Given this list of marker genes LRIG1, PGR, MYLK, HEYL, SCX, MYH7, CEMP1, SLC24A4, HES1, ATP6V1B1, PBX1, FGF1, PAX5, ITGAX, RBP4, HDAC1, ADAMTS1, MEIS2, STAT5A, ATG9B, GRXCR1, ABLIM1, IFT52, PTN, LAMB1, HLX (NCBI Gene Id 3142), RPGRIP1, ENSG00000274276, EFNA1, BTRC (beta-transducin repeat containing E3 ubiquitin protein ligase), CELSR1, FOXD1, STAU2, NOS3, NKD1, ID4, GAA, TNFSF11, HAND2, USH1C, DLX5, E2F4, HIPK1, ELF3, SOS1, TPM1, POC1A, GCNT3, NKX6-1, GATA5, ITGB4, LTBP3, CFLAR, ZMPSTE24 (zinc metallopeptidase STE24), HOXA1, ADAMTS19 (NCBI Gene Id 171019, ADAM metallopeptidase with thrombospondin type 1 motif 19), COL8A1 (collagen type VIII alpha 1 chain), NACA, WT1, NOG, PALB2, MTHFD1, APCDD1, DGCR2, TBR1, APLP1, ERBB4, ODAPH, COL8A2, DLL4, AKT3, WNT4, SAV1, RPS6KA1, PEX7, SCRIB, EYA1, AMELX, TP63 (tumor protein p63), APC, SOX18, GRHL3, EFEMP2, ALPL, BBS1, EPHA2, ZFPM1, DCHS1, COL5A2, INHBA, LIF, TBX18, ASXL1, TGFA, RAC1, MDFI, JAG2, BCAR3, NKX2-5, RPGRIP1L, KCNQ4, CRYAA, DSPP, FLI1, MAP2K2, GNAT2, ZNF335, MDM4, TEAD2, GDNF, CPLANE2, BRAF, RNF207, GLG1, C2CD3 (C2 domain containing 3 centriole elongation regulator), HOXA4 (NCBI Gene Id 3201), CRYGB (NCBI Gene Id 1419), FZD2, FOXL2, PPP1R13L, PLXND1, COL13A1, FOXG1, SMAD7, LRP4, BMP2, TTN, HOXC8, HDAC2 (histone deacetylase 2), RFLNA, SOBP, NTN1, EFEMP1, AQP3, ENAM, MYH6, SETDB2, CRB1, STOX1, IL6, LRP5, SLC4A2, SLIT1, SOX4, FGD1, NDST1, RAB33B, UCHL5, NGFR, LGR4, HOXA7, COL2A1, TNFAIP3, EFNB2, SIX4, TMEM100, TH, DYNC2I1, ONECUT2, ZNF22, SLC4A10, HOXB2, EREG, SLC1A1, NTRK2, LTF, PROM1, CPE, TECTA, PKD2, BSG, HOXD9, SMARCC1, NHERF1, PHLDA2, ROBO1, TNF, CSF1R (colony stimulating factor 1 receptor), PITX3, MTOR, TWIST1, RFNG, PAX6, TEK, LEFTY1, POU5F1, BCL2, ARL13B, HEY2, BMP1, TDRD7, NR5A2, EXT2, SNAI1, TULP1, ABCC9, LHX1, HOXB5 (homeobox B5), WLS, CTNNBIP1 (NCBI Gene Id 56998), SOX17, MFRP, ANKRD1, SDK2, NPPC, BSX, FBN1, DSCAML1, TBX5, SERPINH1, ATF2, BARX2 (BARX homeobox 2), FGF4, SLIT3, HOXC11, ZFPM2, LY6H, ARL6, MYL11, KLHL3, RS1, LFNG, MGP, CRIP1, MAPK3, TGFBR2, RUNX2, HOXD13, MAN2A1, GMNN, AJAP1, WNT16, ACVR2B, NPNT, AGT, HOXD8, TMEM59L, MYO15A, COL5A1, BCR, MIR145, BPNT2, FGF16, RYK, NKX2-3, KLHL10, NRP2, FAM20A, FZD1, MIR1-1, AMTN, C12orf57, NF2, TFAP2A, PDX1, PAX3, CHAD, HGF, MSX2, IRX2, MIR17HG, S1PR1, CRX (cone-rod homeobox), WWOX, NTF4, EXT1, XBP1, SEMA3C (NCBI Gene Id 222200), PPARA, RORB, RARB, MED1, SP7, ESR1, FOXI1, HOXD10, ROBO2, FEM1B, NAGLU, BBS4, TAB1, PPP3CA, EDAR, TIPARP, STIL, TGFB1, DCN, RPL13A, ELN, SLC6A4, AHDC1, PBX3, HCCS, FUZ, WHRN, PHOSPHO1, HOXB3, CUL1, THRA, BMPR2, RTN4, BMP5, NR4A3, HACD1, FOXP2, CCN1, ATF4, NR2E3, THRB, CHRNA10, IRX3, MIB1, CLDN5 (NCBI Gene Id 7122), MYF6, ALPK2, OTX1, GPC3, TUFT1, ABI2 (NCBI Gene Id 10152), STC1, CER1, VAX2, TMEM176B, SERPINE1, FRAS1, CTNNA1, AREG, FHL1, PAFAH1B1, FOXI3, PAX4, ISL1, MIR20A, IFT172, HPN, PRKRA, ERRFI1, COL27A1, FGFR1, CELA1, CHSY1, HOXD4, GRHL2, HOXD11, FOXC1, EXOC4, CRKL, NPY2R, TFAP2B, SAMD7, RHOA, TGFBR1, BBS10, MSX1, MDK, SOSTDC1, TNNI3, CNNM4, MESP2, DKK1, KRAS, IMPG2, TRIOBP, TBXT, SEMA6A, NF1, ETV5, NOTO (notochord homeobox), PAPPA2, EZR, HCN1, RFLNB, RP1, MEGF8, FOXJ1, ADAMTS9, BCL11B, VEGFA, IRX5, HOXA5, RBM15, LRP2, DVL2, RING1, PLEKHA1, SOD1 (superoxide dismutase 1), OLFM3 (NCBI Gene Id 118427), IFT57, FGF6, SP5 (Sp5 transcription factor), MMP13, LHX9, DLX1, ITGA2, PTCD2, UBE4B, PDGFRA, SP3, TMEM107, SPARC, DLG5, PKP2, TGFB2, FZD6, SOX11, SMAD6, NECTIN3, FKBP1A, PPP1R35, SRSF6, LAMA1, DLC1, MIR17, BTBD7, STX2, NAB1, CLRN1, WNT10A, MAGED1, CUL3, AGTR2, NOTCH1, AQP5, CBS, TMEM215, HMX2, INSIG1, EMX1, RHO, ROM1, HIPK2, MESP1, FGF7, VEGFC, IRX4, GLI3 (NCBI Gene Id 2737), KDM2B, PDE6C, NDP, FGFR3, BMI1, KIF26B, FOXA1, MSN, HOXB13, DSP, EIF4A3, CDX2, TCF21, PRICKLE1, RXFP1, BMPR1A, DMRT3, MYO3A, DIO3, FLVCR1, CEBPB, RYR1, SKI, ENG (endoglin), SFRP1 (secreted frizzled related protein 1), CEP290, ALX1, STAT6, PTPRM, SPRY2, SNAI2, HOXA11, ANKH, CSGALNACT1, RARA, EPHB1, PHACTR4, PROX1, CCDC39, RAB37, KLK5, ADAM15, SMTNL1, LEF1, WDPCP, PLS1, SAMD11, ASXL3, BMP6, TCF15 (transcription factor 15), FOXF1, FSCN2, HMGN1, TRAF6, FOXN3, ASXL2, ACTA1, BBS2, SALL1, AXIN2, VPS51 (VPS51 subunit of GARP complex), ODAM, TSKU, ALDH1A3 (aldehyde dehydrogenase 1 family member A3), CDKN2A, PAX7 (paired box 7), RARG, PHB2, MEF2C (NCBI Gene Id 4208), SLIT2, DLX6, FGR, NPHP3, TNC, FST, GSK3A, CRB2, COL6A1, MIR19A, BMP4, FHL2, CALB1, NTN4, GDF11 (growth differentiation factor 11), POR, FGL1, SLC39A1, HS3ST3B1, SHOX2, GHR, CHD7, GATA3, ZHX2, WNT9A (Wnt family member 9A), DAG1, TCAP, MEIS3P1, IFT80, BCL2L11, AQP6 (NCBI Gene Id 363), CDC42, PSEN1, PRDM1, TBX2, NPR2, CNTF, ZMIZ1, FGFR2, POU3F4, DMP1, ROGDI, SP6, SPEF2, FGF18, HOXB8, STK40, NCKAP1, NEDD4, NKX2-1, CDH23, CSF1, TMIE, MYBPC3, SLC44A4, USH1G, DLX2 (NCBI Gene Id 1746), ALX3, RIPPLY2, TLE1, MMP2, ARID5B, COL3A1, SGPL1 (NCBI Gene Id 8879), SIX1, COMP, FANCD2, CERT1, WDR48, TGFBR3, TSHZ1, CDON, MYF5, OTOP1 (otopetrin 1), SFRP4, AQP1 (NCBI Gene Id 358), STRA6, TBX15, SLITRK6, NDRG4, ATP8A2, HOXA2, CTHRC1 (NCBI Gene Id 115908), NEUROG1, ITGA6, SOX9, SYNPO2L, TLE2, COL11A1, P2RX7, ACTC1, MTHFD1L, YAP1, CLUAP1, GNGT1, GREB1L, SOX12, CAV1, GAMT, AGTPBP1, TBX3, LIPA, INSR (NCBI Gene Id 3643), ADARB1, MAP2K1, COL1A1, PLXNA1, LIMS2, GRXCR2, FOXE3, FGF10, NRP1, HOXA9, MAPK14, IGF2, HEG1, BBS7, HOXB4, CTNNA2, FZD3, NEUROD1, ALX4, TBX4, ASB2, TNNC1, HS3ST3A1, BMPR1B, MAPK1, ZIC3, EMP2, HOXC13, OSR2, MMP20 (NCBI Gene Id 9313), SIX3, TP53, PTK2, MED12, NRG3 (NCBI Gene Id 219505), SSUH2, TBC1D20, NODAL, WNT2B, TBX1, HRAS, TBX20, NPY1R, PTEN, EP300, COL18A1, REST, GNAT1, TBX19, AMBN, ID1, SHROOM2, CDX1, FBN2, ACVRL1, DNAH11, FAM20C, COL9A1, PKHD1, TLE3, FREM1, JHY, SMAD2, ABCA12, MIR21, LRRK2, AP3B1, WNT7A, SIX6, TAF10, HAS2, LBX1 (NCBI Gene Id 10660), FLRT2, AHI1, GMPPA, JAG1, WWTR1, HESX1, HOXB1, MIR19B1, TCIRG1, TGM2, SAPCD2, ADAMTS5 (NCBI Gene Id 11096), BBS5, RDH13, SYCP2, TNNI1, SLC39A3, HOXC9 (homeobox C9), HOXB7, TMT1A, FGFRL1, HMGA2, GSX2, GATA2, HAND1, TNNT2, WNT7B, LHFPL5, DLG1, HHIP, PRKCI, YY1, SPRY1 (NCBI Gene Id 91129), ARID2, MYO3B, ATG9A, MATN1, ZEB1, SNX10, RELT, NSD2, CITED1, HOXA3, RBPJ, BAX, SOX8, CD34, MKS1, PERP (NCBI Gene Id 64065), TRPV4, CTSZ, RYR2, THY1 (NCBI Gene Id 94105), NFIB, NPY5R, TTC8, DNAAF1, WNT9B, SRC, ADAMTS16, SRF, CAPN1, TNFRSF11B, HNF1A, ZFAND5, GDF7, PAX9, SMO, PRRX1, CCDC40, SATB2, ITGB6, FOXC2, STIM1, HEY1, SFTPB, SOX1, VSX1, XIRP2, FASLG, NFKB1, ACVR1, ADGRG6, EGLN1, ILK, SDK1, DHRS3, SCN10A, STAT3, PAX8 (paired box 8), MEGF11, MDM2, FGF2, NECTIN1, SERP1, SCN5A, CYP7B1, CTSH, MIR195, CEACAM1, INSIG2, HTR2B, FJX1, STRC, DGCR6, DVL1, AMELY, AR, IFT122, BAK1, RELA, ADPRHL1, ACTN3, WNT11, FAT1 (NCBI Gene Id 2195), MYL2, TREH, FRS2, FGF9, CCN2, CTNNB1, MEIS1, PDGFC, TRIP11, FOLR1, ESRP2, CFTR, INPPL1 (inositol polyphosphate phosphatase like 1), SULF2, PLAG1, DDR1, ACVR2A (NCBI Gene Id 92), VDR, MMP14, MFAP2, GBX2, SOX6, BMP10, MKKS (MKKS centrosomal shuttling protein), STAT1, KDM5B, MYC, OLFM1, PTCH1, PDCD4, IFT140, HYAL1, FOXN1, RBM20, PLOD3, CCL11 (NCBI Gene Id 6356), PIM1, BLOC1S5, WNT3A, HIF1A, CABP4, GCNT1 (glucosaminyl (N-acetyl) transferase 1), MYL3, GSC, GLI2, BASP1, ID3 (inhibitor of DNA binding 3), INTU, POC5, EDNRA, MFAP5, SMAD3, FOXH1, FKRP, TPRN, FOXE1, POU4F1, TENM3, PTF1A, MFN2, BMP7, ACP4, ITGA8, MYO7A, PML, SFRP2, MIR143, POU4F3, APLNR (apelin receptor), TWSG1, LHX3, NRG1, RSPO2, CDH2, JUN, TSPAN12, TFAP2C, TULP3, EPHB4, WDR19, NKX3-1, ETV7, SMAD4, RAB23, DSCAM, TIFAB, PKD1 (NCBI Gene Id 5310), GBA1, NIPBL, KLK4, MMP16, HOXB9 (homeobox B9), SERPINB5, IRX1, FAT3, OVOL2, FGF8, SMARCD3, NFIC, CSRNP1, TREX1, SHH, FOXN4, OSR1, HNF1B, LARGE1, CAV3, SEC24B, HOXB6, KCNJ8 (potassium inwardly rectifying channel subfamily J member 8), GCNT4, EVA1A, WNT6, SYK, SLC40A1, MAFB, NKX3-2, SULF1, KCNQ1, PRKX, LAMA5, ACTA2, CHST11, HOXA13, NR3C1, MYLK2, SOX5, ALDH1A2, TUBA1A, VANGL2, PBX4, GLI1, RDH10, FOSL2, FZD5, NLE1, PBX2, PDGFA, FOXF2, PCGF2, ATOH1, LHX4, FBXW11, VSX2, HMX3 (NCBI Gene Id 340784), CCM2L, PPP2R3A, HES5 (NCBI Gene Id 388585), GATA4, NOTCH2, GJA5, KDR, POLB, FBXW7, GALNT3, ANKRD11, CITED2, CCL2, EMX2, HOXC4, PROP1, ACTG2, LEMD2, HYAL2, PAX2, TTC39C, EDA (ectodysplasin A), WNT1, UNCX, SHANK3, NEK8, MEIS3, GJB6, IGF1, FOXO3, TSPEAR, IFITM5, TGFB3, IGFBP5, ANKRD24, OTOR, DLX3, WNK4, SLC34A1, CCDC103, MYO6, HOXD3, WNT10B, DZANK1, CSF3R, E2F5, RBPMS2, LRIG3, HS2ST1, FRZB, EVL, PDZD7, ZIC1, EGFR, SIX2, CDSN (corneodesmosin), COL1A2, LCTL, GATA6, BCOR, THBS3, CLRN2, SMPD3, NAB2, PARVA, VPS33B, ACP5, TACSTD2, CYP26B1, ID2, ASPN, WNT2, MICAL2, TMED2, DLL1, CHRNA9, CSMD1, MFSD2A, TMEM119, NRL, EPHB2, GZF1, SUFU, IL7, C10orf71, ASH1L (NCBI Gene Id 55870), PITX2, IHH, PHEX, PTK7, EDN1, RPGR, GREM1, MYCN, WNT5A, DCANP1, LZTS2, RPL38, here is a description of the gene set: studied in species Homo sapiens Morphogenesis of an animal organ. An organ is defined as a tissue or set of tissues that work together to perform a specific function or functions. Morphogenesis is the process in which anatomical structures are generated and organized. Organs are commonly observed as visibly distinct structures, but may also exist as loosely associated clusters of cells that work together to perform a specific function or functions. Human Gene Set: GOBP_ANIMAL_ORGAN_MORPHOGENESIS